Given this list of marker genes POLR1G, TAF1A, TAF1B, TBP, TAF1C, TAF1D, here is a description of the gene set: Human Gene Set: GOCC_RNA_POLYMERASE_I_TRANSCRIPTION_REGULATOR_COMPLEX species: Homo sapiens A transcription factor complex that acts at a regulatory region of a gene transcribed by RNA polymerase I.